The following is a description of a gene set: Aplasia/Hypoplasia of the lungs Human Gene Set: HP_APLASIA_HYPOPLASIA_OF_THE_LUNGS species: Homo sapiens, and this is the list of marker genes: NSDHL, NAA10, ESAM (endothelial cell adhesion molecule), TRIP11, IFT81, AARS2, STRA6, ACE, SLC18A3, ATP5F1A, RLIM, PORCN, KLHL41, LMNA, WT1, ASCC1, PRRX1, AGTR1, TBX4, MAGEL2, LETM1, WNT7B, RSPO2, ALDH1A2, TBX1, DLK1, CPLX1, NSD2, WDR19, RAPSN, ZMPSTE24, FANCB, GRIP1, DYNC2I2 (dynein 2 intermediate chain 2), GBA1, TRPV4, GLE1, SMO, VANGL1, TTC21B, LMOD3, FUZ, NEK9, EVC (EvC ciliary complex subunit 1), FLNA (filamin A), GATA6, LBR, GLI1, FGFR3, COL2A1, CEP55, PTH1R, ETFA, FREM2, CEP120, ITGA8, KAT6B, TMEM94, COQ7 (NCBI Gene Id 51672), KIAA0586, ADGRG6, LTBP4, REN, PIGN, SPECC1L, TUBA1A, GREB1L (GREB1 like retinoic acid receptor coactivator), PI4KA, GPKOW, SF3B2, WNT9B, MCTP2, IFT172, PIGG, MYRF, CSPP1, FLNB, KIAA0753, SLC25A24, NELFA, MUSK, MKS1, SETBP1, ALG3, RYR1, NKX2-6, SLC26A2, CHRNG, GLDN, INTU, TCTN3 (tectonic family member 3), AGT, SON, WDR35, CC2D2A, DPAGT1, PKHD1, RET, PHGDH, CTBP1, B3GALT6, RARB, EVC2, PRKACA, IFT80, INVS, ACTA1, IFT140, TAPT1, NPHP3, LONP1, ZFPM2, MEG3, ALG9, ETFB, PLXND1, FRAS1, HSPG2, CTNNA2, MYOD1, ETFDH, LIFR, PEX1, DHCR7, SLC31A1, ZIC3, FGF20, NDUFB10, MYH11, FAM20C, NUP88, DYNC2LI1, NEK8, BMPER, CHRNA1, CHRM3, WNT3, MYH3, PIEZO2, NEK1, BCOR (NCBI Gene Id 57686), KIF21A, RBM10, DYNC2I1, DZIP1L, PRKACB, CHRND, MKKS, DYNC2H1, DOK7, CDC45, WNT4, RTL1 (NCBI Gene Id 651665), NEB, DONSON, LGI4, TXNDC15, TRIP4, HOXD13, SCN4A, GFRA1, KLHL40